The following is a description of a gene set: Low APGAR score studied in species Homo sapiens Human Gene Set: HP_LOW_APGAR_SCORE, and this is the list of marker genes: SNORD115-1, SNORD116-1, FGFR3, PWRN1, PWAR1, USP9X, MCTP2, MTM1, HERC2, PDHA1 (NCBI Gene Id 5160), ALDH7A1, MKRN3, PLPBP, PNPO, NPAP1, LONP1, PRPS1, MAGEL2